The following is a description of a gene set: A filament composed of acidic and basic keratins (types I and II), typically expressed in epithelial cells. The keratins are the most diverse classes of IF proteins, with a large number of keratin isoforms being expressed. Each type of epithelium always expresses a characteristic combination of type I and type II keratins. species: Homo sapiens Human Gene Set: GOCC_KERATIN_FILAMENT, and this is the list of marker genes: KRT73, KRTAP4-16, KRT7, KRTAP4-8, KRTAP26-1, KRT1, KRTAP1-1, KRTAP10-3 (keratin associated protein 10-3), KRTAP10-10, KRTAP24-1, KRTAP3-3, KRT86, KRT82, KRTAP4-12, KRT3, KRTAP11-1 (keratin associated protein 11-1), KRTAP10-2, KRT83, KRTAP4-4, KRT6C, KRTAP4-5, KRT8, KRTAP10-6, KRT14, KRTAP13-2, KRT25, KRTAP2-1, KRTAP9-8, KRTAP9-4, KRTAP13-1, KRT5, KRT74, KRTAP12-1, KRT76, KRTAP10-12, GPER1, KRT2, KRTAP3-1, KRTAP10-4, KRTAP10-8, KRT16, KRT77, KRTAP9-3, KRTAP10-7, KRT79, KRTAP10-1 (NCBI Gene Id 386677), KRTAP2-4, KRTAP10-9, KRT9, KRT18, CSNK1A1, KRTAP4-1, KRTAP9-6, FAM83H, CASP14 (caspase 14), KRTAP25-1, KRTAP1-5, KRT4 (NCBI Gene Id 3851), KRTAP9-1, EPPK1, KRT13, KRT81, KRTAP10-5, KRT6B, KRT78, KRT36, KRTAP2-3, KRTAP29-1, KRT71, KRT84, KRTAP27-1 (NCBI Gene Id 651759), KRT87P, KRT85, KRTAP4-9, KRT75, KRTAP3-2, KRT72, KRTAP4-11, KRTAP1-4, KRTAP16-1, KRTAP9-7, KRTAP1-3, KRT80, TCHP, KRTAP9-9, KRT6A, KRTAP4-2, KRTAP4-3, KRT10, KRTAP10-11, KRTAP12-3, KRTAP9-2, KRTAP4-6, FBF1